The following is a description of a gene set: species: Homo sapiens Human Gene Set: GOCC_VESICLE_LUMEN The volume enclosed by the membrane or protein that forms a vesicle., and this is the list of marker genes: APAF1, RNASE2, GAS6, SERPINF2, CYB5R3, GDI2, HSP90AA1 (heat shock protein 90 alpha family class A member 1), PYCARD, GHRL (ghrelin and obestatin prepropeptide), OLA1, ARSA, B2M, CRH, PKM, GPI, TIMP1, GLB1, DEFA4, GCA, MNDA, TGFB3, ITIH3, APOA1, EGFR, ALDOC, ACTR1B, TRAPPC1, NEU1, RAB27A, GSN, ITIH4, ALOX5, THBS1, VCP, SERPINA3, APP, ALAD, ADA2, MMRN1, SERPINB1, PROS1, VEGFD, ACTN2, ISLR, PRF1, GALNS, PLG, KNG1, HPSE, SPTAN1, NHLRC2, LRG1, MPO, COMMD9 (NCBI Gene Id 399879), CCT2, FGR, QSOX1, CTSG, PF4, SDCBP, CLU, ALDOA, DNASE1L1, NME2, VEGFC, SERPINA1, CDA, DEFA1 (NCBI Gene Id 504182), HEBP2 (heme binding protein 2), SERPING1, PSMD12, ARHGAP9, CREG1, CAND1 (NCBI Gene Id 55832), GZMB, DBH, KPNB1, FABP5, PSMB7, MIF, GIP, PYGB, FUCA1 (NCBI Gene Id 2517), PSMD2, CTSW (cathepsin W), PSMD3 (proteasome 26S subunit, non-ATPase 3), PSMD7, GUSB, GLA, BACE1 (beta-secretase 1), DPP7, DERA, TTR, EEF1A1, UNC13D (NCBI Gene Id 201294), VAT1, ARG1, DEFA5, F5, CCT8, ADM, FAM3C, FERMT3, FASLG, PSMA5 (NCBI Gene Id 5686), MAPK14, ORM2, ACTR10 (NCBI Gene Id 55860), GSTP1, A1BG, DEFA1B, AGL, EPX, CYFIP1, PSMA2, EEF2, HSPA6, TOR4A, GMFG, CPPED1, FGG, FCN1, PDXK, PA2G4, DOCK2, CTSD, GTPBP2, SERPINI1, VWF, PDGFA, PSMD6, DDX3X, S100P, PNP, SRP14, CRISP3, HSP90AB1, PSMC3, S100A9, DSN1, NHLRC3, FRK, GGH, CTSC (cathepsin C), SELENOP, BIN2, ILF2, PRTN3, HEXB, TGFB2, IST1, PRSS2, ACTN1, CNN2, IMPDH1, ATG7, AGA, CHIT1, NFKB1 (NCBI Gene Id 4790), ACLY, DYNC1H1, PCYOX1L, GHDC, STK11IP, HK3, EGF, PTX3, GRP, GYG1, FOLR3, VEGFB, TUBB4B, PGLYRP1, PSMD11, SPACA7, LCN2, FN1, IDH1 (isocitrate dehydrogenase (NADP(+)) 1), PSMB1, OSTF1, SPP2, LRRC7, C1orf35, CHI3L1, ACTN4 (NCBI Gene Id 81), IMPDH2, HSPA8, F13A1, ELANE, TEX264, CTSA, PTPN6, BPI, PGM2, DEFA3, S100A11, PGAM1, CFP, GM2A, CRACR2A, XRCC6, ARMC8, MMP8, MAPK1, GCG, ECM1, VTI1B (vesicle transport through interaction with t-SNAREs 1B), TCN1, C6orf120, AHSG, HMGB1, DYNLT1, NIT2, PPIE, ACTR2, PRKCD, PRSS57, GRN, FAF2 (Fas associated factor family member 2), SERPINB3, PCSK1, CAMP, FUCA2, CAP1, ROCK1, SERPINE1, PRG3, S100A8, CXCL1, ALB, ARHGAP45, TIMP3, HGF, SERPINA4, INS, ORM1, SLPI, JUP, HP, ADA, PTGES2, AOC1, AMPD3, CANT1, CRISPLD2, TXNDC5, PPBP, OLFM4, GNS, CLEC3B, SCG3, LTF, HCRT, CDC37L1, ANXA2, MAGED2, RNASE3, CEP290, POMC, TF, ARPC5, PLAC8, APOH, VEGFA, NPC2, XRCC5, PYGL, FGB, LEFTY2, DBNL, FTL, CAT, CTSH, VCL, GSDMD, PDGFB, TUBB, PRDX6, APOOL, IGF1, PAFAH1B2, TGFB1, CAB39, OSCAR (NCBI Gene Id 126014), SRGN, A2M, LYZ, C3, CFD, APRT, HRNR, AZU1, COTL1, FGA, PSMD13, ARSB, RNASET2, MVP, PADI2, ERP44, CSTB, S100A7, PENK, MAN2B1, CYRIB, TOLLIP, IGF2, TIMP2, LGALS3BP, PSMD14, HRG, RETN, DNAJC3, PPIA, HUWE1, PFKL, ACAA1, PRDX4, TMSB4X, PSMD1, CTSZ, PSMC2, NAPRT, VPS13A, SCCPDH, CSNK2B, QPCT, RARRES2, F8, S100A12, SPARC